Given this list of marker genes Scrib, Cacna1a, Ascl1, Cdk5r2, Bcl2, Uqcrq, Phox2a, Atf2, Hoxb1, Cdk5r1, Hoxa1, Slc4a7, Grin1, Sec24b, Kcne1, here is a description of the gene set: The process whose specific outcome is the progression of the pons over time, from its formation to the mature structure. The pons lies above the medulla and next to the cerebellum. The pons conveys information about movement from the cerebral hemisphere to the cerebellum. species: Mus musculus Mouse Gene Set: GOBP_PONS_DEVELOPMENT